The following is a description of a gene set: studied in species Homo sapiens Interaction of hematopoietic progenitors with the thymic stromal microenvironment induces them to proliferate, adopt the T cell fate, and asymmetrically diverge into multiple T lineages. Progenitors at various developmental stages are stratified among different regions of the thymus, implying that the corresponding microenvironments differ from one another, and provide unique sets of signals to progenitors migrating between them. The nature of these differences remains undefined. Here we use novel physical and computational approaches to characterize these stromal subregions, distinguishing gene expression in microdissected tissues from that of their lymphoid constituents. Using this approach, we comprehensively map gene expression in functionally distinct stromal microenvironments, and identify clusters of genes that define each region. Quite unexpectedly, we find that the central cortex lacks distinctive features of its own, and instead appears to function by sequestering unique microenvironments found at the cortical extremities, and modulating the relative proximity of progenitors moving between them. from publication Griffith AV, Fallahi M, Nakase H, Gosink M, Young B, Petrie HT (PMID 20064453) Genes up-regulated in thymus: whole cortex versus whole medulla. Human Gene Set: GSE18281_CORTEX_VS_MEDULLA_THYMUS_UP, and this is the list of marker genes: IL6 (NCBI Gene Id 3569), DEDD, ZHX3, ZMYND19, PRDM15, FOXM1, SLC22A4, MSH6, BRD9, FBRSL1, ZFPL1, SYT14, NKX2-8, SCP2, KLRD1, OR7C1, DDX17, SLC15A4, KLHL6, WASF3, XYLT2, DHX30, SDCBP2-AS1 (NCBI Gene Id 100507495), MAGI2, RBM26, ARMCX3, MAP1LC3A, CRY1, TUT4, PLEKHJ1, ANXA2R, CNIH1, TP53BP1, BMI1, PSMA3-AS1, DCAF8, USPL1, OPHN1, SPMIP10, MBD4, EXOSC7, KRT35, ALOX12P2, ENPP6, RARB, CDHR5, AMPH (amphiphysin), HSPA12B, SRD5A1, ZNF879, B3GNT3, CINP, KLHDC8A, LINC00929, PPP4R3A, TFAP2B, HYOU1, ERP29, EDEM3, PABIR2, IL15, GNG12, TFRC, UHMK1, IFT80, ANKRD27, DNAJB6, BABAM1 (NCBI Gene Id 29086), ZBED6, HLA-G, PLCB1, RANBP3L, TTC29 (tetratricopeptide repeat domain 29), IPO8, P4HA1, TPRG1L, ZBTB49, PPHLN1 (NCBI Gene Id 51535), CALCR, AMELY, DYNLT3, FAM216A, MAS1, MAP2K1, TRAF4, KLRG1, ZNF29P, HLA-C, RABGGTB, SUCNR1, OPALIN, IL15RA, WDFY3-AS2, IWS1, MICU2, ZSCAN29, MYBPC2, GCDH, EID3, PTDSS1, C19orf12, ZNF615, LYST, ADAM20, ARF1, TBC1D4, STAG1, KLHL2, TRA2B, FGF14, RB1CC1, CTSK, PPP1CC, SLC12A9, RPS6KB1, EXOSC3, LBR, UCKL1, PSMD6, TBL1Y, DTX1, TMEM255A, UBL3, NEK7, SUMO4, EML4, NUP188, PRIMPOL, TEFM, LRRC2-AS1, KRBA2, LINC01118, R3HDM1, SP2-AS1, FMR1, VN1R4, HTR1E, CLPTM1L, AEBP2, SLC38A7, GIT2, FXYD3, EEF2KMT, ZZZ3, PRKX, YTHDC2, PRKCSH, SIK1, INSM1, IGSF22, HNRNPM, PRR23E, EFHC1, PCED1B, DNAAF5, ENTR1, CCL8, TIAM1, SH3RF1, CUL1, NMUR2, EWSR1, PPP1R14D, COL4A2, SERPINB5, COX10, MED21, ZFAND5, BCAM, RTL8C, FGF13-AS1, SLC7A2 (NCBI Gene Id 6542, solute carrier family 7 member 2), PPP2R1B, GS1-279B7.1, PTGS2, LARP4B, PCMTD2, EHD2, PTPN1, HGS, PPP1R21, SEC61A1, RCAN3, SRSF4, ARL5A, RAB40C, LINC00870, DIP2C, COMMD5, ZSWIM3, CACNB2, ASF1B, MIB1